Given this list of marker genes LY6E, IFIT2, PSMA6, UBE2D3, LAP3, TRIM22, IRF9, HSBP1, SP110, XAF1, IFI6, IFIT3, LGALS3BP, MX1, IFI30, ANXA2, IFITM1, MX2, BLVRA, IL1RN, PSMB9, APOBEC3B, IFIT1, USP18, TRIM21 (tripartite motif containing 21), OAS2, TAP1, HERC5, IFITM2, MARCKS, PYHIN1, IFI27, IFIT5, ISG15, SERPINA1, FCGR3A, TNFSF10 (NCBI Gene Id 8743), OAS1, GLRX, IFI44L, VRK2, IFITM3, MT1M, PSME1, CEBPB, LMO2, FPR2, SERPING1, PSME2, PLSCR1, PSMA4, IFI44, CREG1, EIF4A1, CD74, here is a description of the gene set: Gene expression in human peripheral blood mononuclear cells was systematically evaluated following smallpox and yellow fever vaccination, and naturally occurring upper respiratory infection (URI). All three infections were characterized by the induction of many interferon stimulated genes, as well as enhanced expression of genes involved in proteolysis and antigen presentation. Vaccinia infection was also characterized by a distinct expression signature composed of up-regulation of monocyte response genes, with repression of genes expressed by B and T-cells. In contrast, the yellow fever host response was characterized by a suppression of ribosomal and translation factors, distinguishing this infection from vaccinia and URI. No significant URI-specific signature was observed, perhaps reflecting greater heterogeneity in the study population and etiological agents. Taken together, these data suggest that specific host gene expression signatures may be identified that distinguish one or a small number of virus agents. from publication Scherer CA, Magness CL, Steiger KV, Poitinger ND, Caputo CM, Miner DG, Winokur PL, Klinzman D, McKee J, Pilar C, Ward PA, Gillham MH, Haulman NJ, Stapleton JT, Iadonato SP (PMID 17651872) Human Gene Set: SCHERER_PBMC_YF_VAX_AGE_18_40YO_JOINT_TO_VACCINIA_AND_YELLOW_FEVER_UP studied in species Homo sapiens Genes up-regulated in peripheral blood mononuclear cell post-vaccination vs pre-vaccination in adults (18-40) after exposure to YF-Vax, time point anyD. Comment: Significantly Modulated Genes Common to Vaccinia and Yellow Fever Vaccination